The following is a description of a gene set: studied in species Homo sapiens EBV EBNA3C to p27-Cell cycle G1/S. Pathway ID: N00264. Pathway type: Pathogen. Pathway class: nt06165 Epstein-Barr virus (EBV). Pathway Definition from KEGG: EBNA3C -> SKP2 -| CDKN1B -| ((CCNA,CCNE)+CDK2) -> RB1 // E2F Human Gene Set: KEGG_MEDICUS_PATHOGEN_EBV_EBNA3C_TO_P27_CELL_CYCLE_G1_S_N00264, and this is the list of marker genes: CCNA1, CDKN1B, CCNA2, CDK2, CCNE2, SKP2, E2F1, RB1, E2F3, CCNE1, E2F2